The following is a description of a gene set: FoxO family signaling studied in species Homo sapiens Human Gene Set: PID_FOXO_PATHWAY from publication Schaefer CF, Anthony K, Krupa S, Buchoff J, Day M, Hannay T, Buetow KH (PMID 18832364), and this is the list of marker genes: BCL2L11, AKT1, MAPK10, YWHAZ, MAPK8, CSNK1G2, YWHAG, GADD45A, USP7, CSNK1G1, KAT2B, FASLG, CSNK1G3, RALA, CDKN1B, G6PC1, FOXO4, YWHAB, RAN, SGK1, CHUK, CAT, YWHAH, YWHAE, ZFAND5, SKP2, MST1, RBL2, CDK2, RALB, FOXO1, CSNK1A1, CCNB1, FBXO32, CSNK1E, MAPK9, SFN, CTNNB1, XPO1, EP300, SOD2, IKBKB, SIRT1, CREBBP, CSNK1D, BCL6, FOXO3, YWHAQ, PLK1